Given this list of marker genes PLCB3, PRKG2, RSPRY1, LBR, FLNB (NCBI Gene Id 8413), MAX, here is a description of the gene set: species: Homo sapiens Thoracic platyspondyly A flattened vertebral body shape with reduced distance between the vertebral endplates affecting the thoracic spine. Human Gene Set: HP_THORACIC_PLATYSPONDYLY